Given this list of marker genes Ece1, Gbp5, Actr3, Srsf7, Eif1a, Parp11, Dtx3l, Myl12a, Clec4n, Dck, Cxcl9 (NCBI Gene Id 17329), Cd86, Gatm, Plek, Ube2d2a, Psenen (NCBI Gene Id 66340), Itgb1, Fscn1, Nfu1, Iigp1, Txn1, Fgl2, Tubb6, Arap2, Tbc1d1, Bbx, Arfgef1, Atp6v1a, Ak2, Lap3, Usp12, Trim12a, Mitd1, Naaa, Cltc, Ctsz, Apod, Casp1, Creld2, Ndufab1, Nmi, Hnrnph2, Hipk2, Sh3glb1, Trim30c, Fabp5, Ifi206, Fas, Selenow, Fyn, Serpinb9, Arf6, Socs1, Baz1a, Txnrd1, Slamf8, Mapk6, Vim, Rab20 (RAB20, member RAS oncogene family), Ifih1, Slc30a4, Tmem131, Naa20, Rnf19b, Ilrun, Pdcd1lg2, Tma16, Lgals9, Zyx (NCBI Gene Id 97340), Samhd1, Timd4, Fcgr4, Tgm2, Edem1 (NCBI Gene Id 232324), Tapbpl, Zup1, Tgtp2, Jpt1 (NCBI Gene Id 15374), Fbxw17, Kmo, Ctsc, Oasl1, AA467197, Bach1, Atp1a1, Bcl2a1d, Themis2, Lamp2, Clcn7, Calr, Gch1, Nrp2, Gpr171, Samd9l, Tmem184b, Vasp, Msn, Klrk1, Rap1b, Cyp7b1, Xaf1, Crlf2, Sting1, Usp18, B4galt3, Ms4a4c, Atp6v0a1, Jak1, Sp110, Znfx1, Traf1, Cct3, Casp6, Il2rg, Aida, Herc6, Tor1aip2, Shisa5, Anxa7, Acadl, Casp8, Gadd45b, Cycs, Helz2, Psme2, Ccl12, Eif2ak2, H2-K1, Bag1, Scfd1, Ldlr, Ikzf1, Dnaja1 (DnaJ heat shock protein family (Hsp40) member A1), Nampt, Nfkb2, Ly6i, Gbp4, Nr4a3, Lrrc8c, Mllt6, Tor3a, Isg15, Wars1, Vcam1, Gabarap, Ifit3, Socs3, Bst2, Birc2, Phf11d, Crybg1, Gadd45g, Cttnbp2nl, Srgn (NCBI Gene Id 19073), Lcp1, Psma2, Ly6a, Dusp2 (dual specificity phosphatase 2), Rnf114, Slc39a1, Tmbim6, Psmb10, Eif4a1, Tapbp, Gyg1, Sdc4, Vwa5a, Pdia6, Fcgr1, Stx11, Morf4l2 (mortality factor 4 like 2), Il18bp, Rab21, Rtp4, Slc30a1, Grb2 (NCBI Gene Id 14784), Flot1, Tspan13, Crem, Cxcl10, Pafah1b1, Mbd2, Vamp8, Ddx24, Bcl2l11, Psma4, Ifi213, Irgm2, Arf4, Tnfaip2, Ifitm3, Slc26a2, Cebpb, Kdm5c, Riok3, Wdr1, Gbp2, Plaat3, Ccnd2, Il4ra, Batf2, Etv6, Chd7, Birc3, Fcgr3, Ankib1, Jak2, Cxcl16, Serpina3g, Sar1a, Pdcd10, Ogfr, Prkx, Cd300lf, Rars1, Ubxn4, Anxa4, Il15ra, Tnf, Map3k14, Nfkbib, Phf11a, Marchf5, Ifi211, Tnip3, Tagap, Sbno2, Rsad2, Eif5a, Adar, Cacybp, Manf, Irf7, Dok2, Spred1, Rab7, Apol7c, Ifit1, Glipr2, Fnbp1l, Phf11b, Frmd4a, Myd88, Eif4g2, Tcof1, Cd83, Spcs2, Sh3pxd2b, Arid5a, Vav1, Fcer1g, H2-T22, Eif6, Prdx1, Hsp90ab1, Ms4a6d, Cd63, Ifi47, Cyrib, Cd274, Icam1, Ralgds, Spi1, Tpm4, Trafd1, Snap23, Max, Ms4a6c, Pik3r5, Daxx, Igtp (interferon gamma induced GTPase), Rasgrp1, Vdr, Gna13, Etv3, Arl1, Flnb, Slfn9, Slc31a1, Gmppb, Hsp90b1, Tle3, Ifi204, Parp14, Usp25, Pgs1, Nlrc5, Nectin2, Nfkbie, Zc3h7a, Ifi203, Cers6 (ceramide synthase 6), Tpp1, Dhx58, Zfp800, Rab10, Pml, Irgm1, Zc3hav1 (zinc finger CCCH type, antiviral 1), Stat1, Slfn1, Hat1, Stat2, Cstb, Tap1, Cnn3, Gsap, Dnajc2, Marcksl1, Serpina3f, Fam241a, Il18, Cmpk2, Kynu, Atp11b, Arid5b, Efhd2, Ccdc86, Tes, Larp1, Naa25, Ly86, Litaf, Bcl2l14, Cd209e, Ly6e, Etnk1, Kdr, C3, Csrp1, Acer3, Rnh1, Ass1, Ninj1, Orai1, Pcgf5, Sp100, Rigi, Susd6, Basp1 (NCBI Gene Id 70350), Ifi35, Dnase1l3, Tap2, Epsti1, Slfn2, Ube2l6 (ubiquitin-conjugating enzyme E2L 6), Psmb8, Dr1, Snx10, Ccr7, Nt5c3, Nfkbia, Cdkn1a, Nfkb1, Ggct, Lmnb1, Ascc3, Tnfrsf1a (NCBI Gene Id 21937), Ddx60, Dnajb11, Sdc3, Ifit2, Trim30a, Rbbp8, Dok1, Ifi205, Mxd1, Bcl2a1a, Il21r, Pmepa1, Mov10, Isg20, Mt1, Rab5c, Srsf3, Scimp, H2-T23, Skap2, Psma3, Bak1, Irf5, Il10ra (interleukin 10 receptor, alpha), Gda, Tent5c, Trim12c, Ccdc25, Parp9, Psma5, Mapkapk2, Kdm6b, Hck, Sub1 (NCBI Gene Id 20024), Stxbp3, Ccl2, Dnaja2, Slc15a3, Prr13, Mpp1, Sh3bp2, Stat3, Gosr2, Tank, Irf8, Cflar, Rasa4, Pkib, Trappc6b, Gbp3, Tarm1, Mx1, Cdh1, Rap2c, Rap2a, Mndal, Arl8b, Iqgap1, H2-D1, Slc31a2, Nras, Bhlhe40, Ebp, Rnf213, Zfand3 (NCBI Gene Id 99911), Mvp, Rrbp1, Gpr132, Noc4l (NCBI Gene Id 231606), Parp12, Tagln2, Cd40, Oas1a, Csf2rb2, Nup98, Slfn5, Kif1a, Ms4a6b, Tor1aip1, Il4i1, Ccr5, Creb5, Tspo, Sod2, Psmb9, Rmdn3, Adam8, Ppp1r2 (protein phosphatase 1, regulatory inhibitor subunit 2), Fndc3a, Irf1, Oasl2, Il15, Lyn, Lrrk1, Dbnl, Lgals3bp, Procr, Srsf2, Nup153, Actg1, Denr, Dram1, Psmb4, Cggbp1, Cd69, Lilrb4a, Calm1, Slamf7, Oas2, Lcp2, Tpm3, Ehd1, Socs2, Calhm6, Hif1a, Mapk1ip1l, Tmed5, Malt1, Sdcbp, Tpst1, Stat5a, Xbp1, Clic4, Hspa8, Selenos, Ifi44, Tmem106a, Ywhae, Cd53, Camk2d, Psme1, Ifi209, Ywhaz, Trim30b, Lilrb4b, Actr2 (actin related protein 2), Dusp5, Csrnp1, Relb, Elp5, Dnajc13, Ranbp2, Hsp90aa1, Ddx17, Snx2, Clec2d, Nod1, Marcks, Trim30d, Myo1e, Csf2rb, Ifi207, Gbp9, Jaml, Ifitm2, Axl, Traf2, Cfb, Ppa1, Cldnd1, Pnp (NCBI Gene Id 18950), Pim1, Bcl3, Il1rn, Necap2, Sppl2a, Arf1, Med21, Nfe2l2, B2m, Sp140, Ciao2b, Slc2a1, Bcl2a1b, Apobec3, Slfn8, Gbp7, Gbp8, Psma7, Hspa5, Zbp1, Oas3, Ptpn1, Chmp4b, Xdh, Pdk3, Ube2d3, Ugcg, Rhbdf2, Mpeg1, Hprt1, Eif1, Ifitm1, Pfkp, Syngr2, Parp10, Cemip2, Rufy3, Casp4, here is a description of the gene set: studied in species Mus musculus Cytokines mediate cell-cell communication in the immune system and represent important therapeutic targets. A myriad of studies have highlighted their central role in immune function, yet we lack a global view of the cellular responses of each immune cell type to each cytokine. To address this gap, the authors created the Immune Dictionary, a compendium of single-cell transcriptomic profiles of more than 17 immune cell types in response to each of 86 cytokines (>1,400 cytokine-cell type combinations) in mouse lymph nodes in vivo. A cytokine-centric view of the dictionary revealed that most cytokines induce highly cell-type-specific responses. For example, the inflammatory cytokine interleukin-1β induces distinct gene programmes in almost every cell type. A cell-type-centric view of the dictionary identified more than 66 cytokine-driven cellular polarization states across immune cell types, including previously uncharacterized states such as an interleukin-18-induced polyfunctional natural killer cell state. from publication Cui A, Huang T, Li S, Ma A, Pérez JL, Sander C, Keskin DB, Wu CJ, Fraenkel E, Hacohen N (PMID 38057668) Mouse Gene Set: CUI_CDC2_IL15_RESPONSE_UP Genes positively differentially expressed in cell type: cDC2 (conventional dendritic cell type 2) upon treatment with cytokine: IL-15 in mouse lymph nodes in vivo.